The following is a description of a gene set: Human Gene Set: LAKE_ADULT_KIDNEY_C9_THIN_ASCENDING_LIMB species: Homo sapiens from publication Lake BB, Chen S, Hoshi M, Plongthongkum N, Salamon D, Knoten A, Vijayan A, Venkatesh R, Kim EH, Gao D, Gaut J, Zhang K, Jain S (PMID 31249312), and this is the list of marker genes: PEBP1, TPT1, CIB1, AKR1B1, HNRNPM, TPM1, GSTP1, BICC1 (NCBI Gene Id 80114), RPS3, RPL6, CD9, HNRNPU, H3-3B, PFKFB3 (6-phosphofructo-2-kinase/fructose-2,6-biphosphatase 3), HNRNPDL, RPL8, TNFSF10, RPS4X, GAPDH, SAT1, COX4I1, LDHA (NCBI Gene Id 3939), DZIP1, REEP5, RPL3 (ribosomal protein L3), ATP5F1A, ANXA2, ACSL4, PPIA, AIF1L, RPLP0, CIRBP, NPM1, UBE2D3, RPS14, HNRNPC, HSP90AA1, PFDN5, NCL, IGFBP7, YWHAB, EID1, RPL18, MAL2, RPL34, TCIM, RPS25, UBB, KRT7, ATP5F1B, CAST, EIF4A2, EPCAM, APP (amyloid beta precursor protein), MPC2, PKM, SLC25A3, PSMB1, ATP6V0E1, SRSF3, HLA-B, CLDN1, HNRNPR, RTN4, C12orf75, RPL15, S100A6, TMEM59, HSP90B1, DANCR, ATP5MC3, RPS5, TNFRSF11B, SDHA, SF3B1, PDIA6, SERPINA1, SIM2, IFITM3, SYTL2, PLEKHA1, WFDC2, CYSTM1, LAPTM4A, TAX1BP1, RAC1, CD63, TACSTD2, SERBP1, EIF1, RPL19, RPS7, PTMA, RPSA, COX7C, DEK (DEK proto-oncogene), RPS9, SKIL, CYS1, SRP14, RAN, RPS13, PABPC1, EEF2, NAP1L1, MYL6, RPS12, PON2, PTTG1IP, CYB5A, HSPD1, RPS24, RPS11, CALM1, RACK1, SPP1, PSMA7, PPIB, RPL7, RPL7A, RPS23, HSP90AB1, PRDX6, FTL, MAL, HNRNPA2B1, VMP1, RARRES2, JAK1, ANK2, LAMTOR5, HNRNPA3, RPS19 (ribosomal protein S19), RPL21, CCNI, RPS2, EEF1D, RPL32, LYPLAL1, GPX1, SOD2, B2M, RBBP8, UGT2B7, BTG1, CSDE1 (cold shock domain containing E1), RPL14, KIF5B, RPL5, DDX5, SLPI, TPR, UBXN4, RPS15, RPL35, RPS27A, PRDX1, HSPA5, RPL4, CBR1, MYL12B, SLC34A2, RPLP2, NCOA7, GSTM3, RPLP1, SEPTIN11, S100A10, FAU, GDF15, EIF4G2, RPS16, RPS17, ATP6V1G1, RPL9, YBX1, COL4A3, ASPH, TIMP1, HIF1A (NCBI Gene Id 3091), RPS6, PSME1, RPL23, CNBP, PGK1, RPL12, TFPI, RPL11, CD59, HECTD1, VPS13C, NTN4, HOOK1, RPL13 (NCBI Gene Id 6137), TGOLN2, CNDP2, MET, FOXP2, CLDN10, CTNNA1, ZFAND5, PDIA3, XRCC5, ENO1, ERMP1, BEX3, CYCS, ARHGAP29, BTF3, RPL31, IFITM2, CLU, TMBIM6, CCT6A, CD24, RPS18, RSRP1, SLC16A5, RPS20, SARAF, RPL37A, MYL12A, HINT1, RPS3A (ribosomal protein S3A), RPS8, CRYAB, NACA, ACTG1, RPL13A, ALDOA, JTB, UBA52, ARF1, SASH1, TPI1, GOLM1, LDHB, DSTN, RPL10A (NCBI Gene Id 4736), NDUFA4, ITM2B, RPL10, RPL30, VAV3, TGM2, RHOA, TMEM176A, FCHO2, SERF2, GNAS, RPL24, FTH1, ADGRG1, MAOA (monoamine oxidase A), ARHGAP24, OCIAD1, CANX, ATP5F1C, CLINT1, SCCPDH, IVNS1ABP, ANXA5, ANXA4, APLP2, EEF1A1, KRT18, SCIN, SOD1